Given this list of marker genes GPC3, NAA10, LONP1, LAMA3, HS2ST1, FANCA, PIEZO2, MKKS, DDB1, FANCC, MAD2L2 (NCBI Gene Id 10459, mitotic arrest deficient 2 like 2), SMC3, SETBP1, RAB23, BCOR, GLI3, HPSE2 (NCBI Gene Id 7354), BRIP1 (BRCA1 interacting helicase 1), FANCF, ARID1B, PIGN, LAMC2, LAMB3, MYLK, RAD51, EVC2, FANCI, GLI1, FAM20C, PRKACB, FLNA, MBTPS2, AQP2, PALB2, UBE2T, FANCD2, RIPK4, SOS2, GPC4, EDNRA, ERCC8, BRCA2, MED12, RNU4ATAC, PLD1, FANCL, WFS1, AVPR2, MYH11, FANCM, CHRM3, RFWD3, FOXF1 (NCBI Gene Id 2294), XRCC2, ACTB, SOX17, FANCG, PRKACA, ACTG1, DYNC2LI1, NDUFAF3, TBX18, EVC, ACTG2, ERCC4, PIGT, BRCA1, TAF4, BBS12, SLX4, RAD51C, LMOD1, CCNQ, TP63, ERCC6 (NCBI Gene Id 282965), FANCE, FANCB, here is a description of the gene set: Human Gene Set: HP_HYDROURETER The distention of the ureter with urine. studied in species Homo sapiens Hydroureter